Given this list of marker genes Cx3cl1, Cd200r4, Ctsc, Ifnb1, Plcg2, Hspa4, Cst7, Atm, Tnfrsf1b, Csf1r, Cd200l1, Pparg, Tafa3, Syt11, Ptgs2, Cd200r3, Kcnn4, Cd200r2, Cd200l2, Mmp8, Cd200r1, Ttbk1, Cd200, Igf1, Nupr1, Ldlr, Calhm2, Dagla, Sbno1, Sphk1, Trem2, Nr1d1, Lrrk2, Grn, Stap1, here is a description of the gene set: Any process that modulates the frequency, rate or extent of neuroinflammatory response. Mouse Gene Set: GOBP_REGULATION_OF_NEUROINFLAMMATORY_RESPONSE studied in species Mus musculus